The following is a description of a gene set: Human Gene Set: MIR410_5P studied in species Homo sapiens Genes predicted to be targets of miRBase v22 microRNA hsa-miR-410-5p in miRDB v6.0 with MirTarget v4 prediction scores > 80 (high confidence targets). from publication Chen Y, Wang X (PMID 31504780), and this is the list of marker genes: CDKN2B, TOGARAM1, IGLL5, PTPN4, ZNF131, SERF2, SYT9, KRT33B, TMEM115, PIK3R3, TAF5, ALG2 (NCBI Gene Id 85365), HSPD1, CACNA2D1, GORASP2, BOD1L2, ZMYM3, ALDOB, SETD7, P3R3URF-PIK3R3, NLK, DMRT2, PTBP2, SETD5, MEOX2, SAV1, FMN2, RNF24, ARHGAP29, IL1A, GGA2, GATC, CABYR, STK38, RHOBTB1, JAK1, MXD1, ITGA6, BTAF1, PRKCA, PCTP (NCBI Gene Id 94001)